Given this list of marker genes CERS1, MME, OPN5 (NCBI Gene Id 221391), MMP3, OPN1SW, PPID, MMP1, OPN3, CCND1, CRYAA, EGFR, MMP2, AKT1, MMP9, TIMP1, here is a description of the gene set: Human Gene Set: GOBP_RESPONSE_TO_UV_A Any process that results in a change in state or activity of a cell or an organism (in terms of movement, secretion, enzyme production, gene expression, etc.) as a result of a UV-A radiation stimulus. UV-A radiation (UV-A light) spans the wavelengths 315 to 400 nm. species: Homo sapiens